The following is a description of a gene set: Human Gene Set: HP_HOARSE_VOICE species: Homo sapiens Hoarse voice Hoarseness refers to a change in the pitch or quality of the voice, with the voice sounding weak, very breathy, scratchy, or husky., and this is the list of marker genes: LEMD3, AGA, MYH14, STX1A, GDAP1, ELN, SMS, THRA, POU1F1, GPR101, CDC73, LTBP3, GNE, SUZ12, FLNA, MYL2, TPM2, GNPTAB, MFN2, RNASEH2C, NSD1, MLXIPL, RNU7-1, NFE2L2, LAMA3, LTBP4, ECM1, MID1, TSHR, LSM11, RTL1, VPS37D, TMEM270, FBN1, HACD1, FKBP6, RAI1, ACTA1, AFF2, CLIP2, MATR3, ARID1B, METTL27, PPP3CA, HRAS, MEG3, TREX1, GTF2IRD1, ADAR, NKX2-1, LIG4, IDS, KRT6B, IQSEC2, EDA, APOA1, RFC2, MAP3K20, GTF2IRD2, EIF4H, GTF2I, TPM3, AIP, LIMK1, LIFR, SERPING1, KRT5, TRH, SPART, NKX2-5, BUD23, NSUN2 (NCBI Gene Id 54888), RNASEH2A, EZH2, SPTBN1, SLC19A2, LAMC2, KRT6A, TLK2, DNAJC30, FOXE1, TRHR, IFIH1, TBC1D2B, TSHB, KRT16, ACAN, SDHC (NCBI Gene Id 6391), PAX8, BAZ1B, MAPK1, ASAH1, C1R (complement C1r), GPC4, SELENON, DEAF1, PIGN, NCF1, SDHD, DUOX2, SLC26A4, RNASEH2B, TBL2, LAMB3, DLK1, SHOC2, NLRP1, KRT14, KRT17, GPC3, SDHAF2, SLC26A2, TRPV4, SAMHD1, FLII, DDRGK1, ITGA7